The following is a description of a gene set: Type I and type II interferons (IFNs) bind to different cell surface receptors but activate overlapping signal transduction pathways. We examined the effects of a type I IFN (IFN-acon1) and a type II iFN (IFN-g1b) on gene experession in A549 cells and demonstrate that there is a common set of genes modulated by both IFNs as well as a set of gene specifically regulated by each, reflecting the activation of different signaling pathways. In particualr, IFN-g induced many more genes of the signaling pathways, apoptosis, and cytokine interactions than did IFN-a. Even with genes induced by both IFNs there were distinctive quantitativive differences in expression. IFN-g1b plays a major role in the induction and regulation of the complement pathway. Previous work has shown a synergistic antivral and antiproliferative effect of type I and type II IFNs in cell culture and in the treament of tumors in mice. We demonstrate that a majority of genes showed and additive effect of IFN-acon1 and IFN-g1b, but a subset of gene is synergistically induced; these incluce ISG10, MX2, OAS2, and other genes known to be involved in the antiviral response, TRAIL (TNFSF10) and caspases involved in apoptosis and chemokine genes RANTES, CXCL10, and CXCL11. Greater than additive transcription of some of these genes in the presence of both IFNs was confirmed by real-time kinetic RT-PCR. Elevated induction of many of these genes may be sufficient to explain the synergistic antiviral and antitumor effects of this combination of IFNS in vivo. Genes down-regulated in epithelial cells (24h): IFNG versus IFNG and interferon alpha. from publication Sanda C, Weitzel P, Tsukahara T, Schaley J, Edenberg HJ, Stephens MA, McClintick JN, Blatt LM, Li L, Brodsky L, Taylor MW (PMID 16800785) Human Gene Set: GSE5542_IFNG_VS_IFNA_AND_IFNG_TREATED_EPITHELIAL_CELLS_24H_DN species: Homo sapiens, and this is the list of marker genes: RNF39, MFSD3, TEP1, NFKBID, KREMEN1, ATOSA, SOX18, TTBK2, SLC30A9, CCNY, ARHGDIA, HOXA11-AS (NCBI Gene Id 221883), ERN2, PLEKHA3, ESD, MYO15B, EIF4G3, GAN (gigaxonin), NDUFB5, TAF13, TMEM181, WASHC3, TCEAL8, PGF, ZDHHC24, ZNF546, TRAK2, IRS2, RAB3IL1, ZNRF3, USP15, PPP3CC, DGAT2, ANGPT4, CTH, CST8, MPEG1, SLC25A26, EREG, LRRC41, AP1G2, CD22, TMPO, KRT31, SELENON, LRCH1, LANCL3, SPICE1, XRN2, CA2, SPINK4, LMBRD1, SANBR, HS3ST3B1, MEF2B, RRP7A, PLXDC2, HEPACAM2 (HEPACAM family member 2), RXYLT1, MKNK1, FIG4, ARSI, SOCS6, FABP5, TSR1, CYB561A3, SHISA2 (NCBI Gene Id 404758), SMIM19, IL4I1, GCSH, GCM1 (glial cells missing transcription factor 1), GALNT6, THUMPD1, ST8SIA6, KIFAP3, ZNF330, TESK1, EPM2A, SPSB1, EEF1D, SBNO2, BTBD3, UBE4A, GPR89B, FADS1 (NCBI Gene Id 3992), SLC5A8, ZSCAN25, PTCH1, LAMC2, CD69, GPR45, NT5C, MFHAS1, DECR2, UGP2, OLFML2B, ALDOB, TNFAIP1, SNAPC1, ESRP1, AP5S1 (NCBI Gene Id 55317), CCDC102A, B3GALNT1, SLC13A1, PLEKHM3, TBX21, CCN1 (NCBI Gene Id 3491), NMT2, NBEA, RFTN1, ATOX1, CBR3, PRRT4, MRPS34, TRIAP1, BATF2, NKTR, C19orf44, PTPN1, SRSF11, RAB35, ZFP64, STARD10, HOOK1, GJA5, PTGFRN, GSK3B, SULT1B1 (NCBI Gene Id 27284), PDHA1, SCD, IRF1 (NCBI Gene Id 96501), UNC13B, MYEF2, SGK2, SMPD3, GCLM, GRB7, MEP1B, TMPRSS2, C6orf132, SPATA7, ZKSCAN4, EIF4E, ACAD10, EIF1, SLC25A39, SSR3, FLNB, HSD17B2, FGFR2, LMNA, IFT74, ABCB7, TPH1, TCOF1, PDLIM5, WSB1, RNF180, KCNK6, ARHGAP30, SGPP2, NAB1, GARIN1B, BMP6, TRPV4, HOOK2, MRPS10, SLC12A5, NRP2, POSTN, HYPK, XPNPEP1 (X-prolyl aminopeptidase 1), MINDY3, FZD1, SAP30, COL3A1, NR4A2, CYBB, PKD2 (polycystin 2, transient receptor potential cation channel), IL12B, GRHL2, RTF1, TMEM192, DDR2, PLEKHN1, MEDAG, DIPK1A, RGL1, CEPT1, NUDCD1, FARP2, CRYL1 (crystallin lambda 1), ABI1, ZBTB37, GPR15 (NCBI Gene Id 2838), LY9, SNX13, ZDHHC12, LHCGR (luteinizing hormone/choriogonadotropin receptor), GLRX5